Given this list of marker genes CAMK2D (calcium/calmodulin dependent protein kinase II delta), JAK2, TGFBR2, CCND2, ID3, CBX4, CDK6, CASP8, here is a description of the gene set: from publication Mikkelsen TS, Hanna J, Zhang X, Ku M, Wernig M, Schorderet P, Bernstein BE, Jaenisch R, Lander ES, Meissner A (PMID 18509334) studied in species Mus musculus Genes down-regulated in the induced pluripotent cells (iPS) and embryonic stem cells (ES) compared to the parental lineage-committed and partially reprogrammed cell lines. Somatic cells can be reprogrammed to a pluripotent state through the ectopic expression of defined transcription factors. Understanding the mechanism and kinetics of this transformation may shed light on the nature of developmental potency and suggest strategies with improved efficiency or safety. Here we report an integrative genomic analysis of reprogramming of mouse fibroblasts and B lymphocytes. Lineage-committed cells show a complex response to the ectopic expression involving induction of genes downstream of individual reprogramming factors. Fully reprogrammed cells show gene expression and epigenetic states that are highly similar to embryonic stem cells. In contrast, stable partially reprogrammed cell lines show reactivation of a distinctive subset of stem-cell-related genes, incomplete repression of lineage-specifying transcription factors, and DNA hypermethylation at pluripotency-related loci. These observations suggest that some cells may become trapped in partially reprogrammed states owing to incomplete repression of transcription factors, and that DNA de-methylation is an inefficient step in the transition to pluripotency. We demonstrate that RNA inhibition of transcription factors can facilitate reprogramming, and that treatment with DNA methyltransferase inhibitors can improve the overall efficiency of the reprogramming process. Human Gene Set: MIKKELSEN_PLURIPOTENT_STATE_DN